The following is a description of a gene set: Human Gene Set: ZIRN_TRETINOIN_RESPONSE_DN Genes down-regulated in MS427 cells (Wilms tumor with normal WT1) after treatment with 10 microM tretinoin (ATRA) for 24 h. from publication Zirn B, Samans B, Spangenberg C, Graf N, Eilers M, Gessler M (PMID 15897880) Wilms tumor is one of the most frequent neoplasias in children. Our previous microarray screening in a large series of Wilms tumors revealed several candidate genes that are deregulated in advanced tumors and are part of the retinoic acid signaling pathway. To investigate whether retinoic acid could be employed as a novel therapeutic agent in these tumors, we treated cultured Wilms tumor cells with different concentrations of all-trans retinoic acid (ATRA) and assessed gene expression changes by real-time RT-PCR as well as microarray analysis. Several genes like RARRES1, RARRES3, CTGF, CKS2, CCNA2, IGFBP3, UBE2C, CCL2 or ITM2B that were previously found to be deregulated in advanced tumors exhibited opposite expression changes after ATRA treatment. In addition to enhanced retinoid signaling, the transforming growth factor-beta (TGFbeta) pathway was strongly activated by ATRA treatment of Wilms tumor cells. Both the retinoic acid and the TGFbeta pathway mediate inhibition of cell growth. These findings represent the first molecular evidence of a potential benefit from ATRA treatment in Wilms tumors. species: Homo sapiens, and this is the list of marker genes: P2RY2, CLTC, PFN1, ABI3BP, C3AR1, GREM1